The following is a description of a gene set: Binding to a LIM domain (for Lin-11 Isl-1 Mec-3) of a protein, a domain with seven conserved cysteine residues and a histidine, that binds two zinc ions and acts as an interface for protein-protein interactions. studied in species Mus musculus Mouse Gene Set: GOMF_LIM_DOMAIN_BINDING, and this is the list of marker genes: Tln1, Ripk2, Isl1, Rph3al, Afdn, Actn2, Ldb2, Ldb1